The following is a description of a gene set: Mouse Gene Set: GOMF_WD40_REPEAT_DOMAIN_BINDING Binding to a WD40 repeat domain of a protein. The WD40 repeat is a short structural motif of approximately 40 amino acids, often terminating in a tryptophan-aspartic acid (W-D) dipeptide. Several of these repeats are combined to form a type of protein domain called the WD domain. studied in species Mus musculus, and this is the list of marker genes: Cdc5l, Cdc5lrt1, Usp47, Cdc5lrt4, Cdc5lrt6, Cdc5lrt7, Cdc5lrt10, Cct6a, Cdc5lrt9, Myb, Cdc5lrt5, Cdc5lrt8, Ddb1